Given this list of marker genes Pola2, Prim1, Rb1, Ppp2r1b, Pola1, here is a description of the gene set: This event has been computationally inferred from an event that has been demonstrated in another species.<p>The inference is based on the homology mapping from PANTHER. Briefly, reactions for which all involved PhysicalEntities (in input, output and catalyst) have a mapped orthologue/paralogue (for complexes at least 75% of components must have a mapping) are inferred to the other species. Reactome Pathway: Inhibition of replication initiation of damaged DNA by RB1/E2F1 studied in species Mus musculus electronically inferred by orthology from the curated human pathway part of: E2F mediated regulation of DNA replication